The following is a description of a gene set: studied in species Mus musculus Mouse Gene Set: chr16C2, and this is the list of marker genes: Gm46542, Gm18495, Cadm2, Speer2, Gbe1, Gm15828, 4930428D20Rik, Gm19082, Gm18496 (NCBI Gene Id 100417272), 4933411O13Rik, Gm24681